The following is a description of a gene set: An abnormality of ocular smooth pursuit characterized by an impairment of the ability to track horizontally moving objects. Impaired horizontal smooth pursuit Human Gene Set: HP_IMPAIRED_HORIZONTAL_SMOOTH_PURSUIT species: Homo sapiens, and this is the list of marker genes: RFC1, POLR3B, ATXN1, STXBP1, EEF2, ATXN2, ATXN3